Given this list of marker genes ENSG00000283674, DNAJC25-GNG10, PTGES2, POLDIP3, ABHD5, PMPCB, MTND5P11, THAP4, MT-TQ, ZNF175, RNVU1-19, ALDH1L2, MT-TK (NCBI Gene Id 4566), ENSG00000283078, MT-TL1, RNU11, MT-TV, MIR3190, MT-ND1, ADARB1, NCKAP1, PIERCE1, MT-TI, MT-ND3, AMD1, KCNT1, TMEM250, ENSG00000232581, MT-ATP6, MT-TM, MALAT1, DNAJC25, DNAJB4, MT-ND2, WDR41, BCAS4, UBALD1, MT-TG, TAF4, SSR4P1, LINC01719, RNVU1-15, CXXC1, ATG4B, KDM3B, LSM11, SLC38A9, LRRC37A5P, RNU5A-1, MT-ATP8, EGR1, PLEKHF2, MT-TS1 (mitochondrially encoded tRNA-Ser (UCN) 1), ARHGAP4, MRPS2, ANO10, BTG3, SRRM3, NSMAF, ZC3H12A, MT-RNR2, KNSTRN, ARHGAP22, ROR2, INTS15, MTCO3P12, TTC1, LITATS1, CLASP1, PTGES2-AS1, MT-CO3, here is a description of the gene set: Human Gene Set: DROSHA_TARGET_GENES Genes containing one or more binding sites for (DROSHA) in their promoter regions (TSS -1000,+100 bp) as identified by GTRD version 20.06 ChIP-seq harmonization. studied in species Homo sapiens from publication Yevshin I, Sharipov R, Kolmykov S, Kondrakhin Y, Kolpakov F (PMID 30445619)